The following is a description of a gene set: Type III interferon signaling species: Homo sapiens Human Gene Set: WP_TYPE_III_INTERFERON_SIGNALING, and this is the list of marker genes: JAK1, IRF9, TYK2, IFNLR1, IFNL3, IFNL1, STAT2, STAT1, IL10RB, IFNL2